The following is a description of a gene set: A protein ubiquitination process in which a polymer of ubiquitin, formed by linkages between lysine residues at position 29 of the ubiquitin monomers, is added to a protein. K29-linked ubiquitination targets the substrate protein for degradation. Mouse Gene Set: GOBP_PROTEIN_K29_LINKED_UBIQUITINATION species: Mus musculus, and this is the list of marker genes: Ube2d2b, Rnf126, Ubr5, Ube2t, Rnf186, Traf7, Ube2s, Ube2srt, Rnf167, Ube3c, Itch